The following is a description of a gene set: UDP-glucuronosyltransferases (UGTs) play a major role in the conjugation and therefore elimination of potentially toxic xenobiotics and endogenous compounds. The 1-4 isoform UGT1A4 is able to act upon lipophilic bilirubin, the end product of heme breakdown. Defects in UGT1A4 can cause hyperbilirubinemia syndromes ranging from mild forms such as Gilbert syndrome (GILBS; MIM:143500) to the more severe Crigler-Najjar syndromes 1 and 2 (CN1, CN2; MIM:218800 and MIM:606785) (Sticova & Jirsa 2013, Strassburg 2010, Udomuksorn et al. 2007, Costa 2006, Maruo et al. 2000). Reactome Pathway: Defective UGT1A4 causes hyperbilirubinemia part of: Metabolic disorders of biological oxidation enzymes species: Homo sapiens, and this is the list of marker genes: UGT1A4